Given this list of marker genes C1ra, Fgg, Fgb, Anxa5, C1rb, Hp, C1rl, Eng, Tgfb1, Fga, here is a description of the gene set: Mouse Gene Set: GOCC_BLOOD_MICROPARTICLE studied in species Mus musculus A phospholipid microvesicle that is derived from any of several cell types, such as platelets, blood cells, endothelial cells, or others, and contains membrane receptors as well as other proteins characteristic of the parental cell. Microparticles are heterogeneous in size, and are characterized as microvesicles free of nucleic acids.